The following is a description of a gene set: Human Gene Set: GOBP_MITOCHONDRIAL_FISSION The division of a mitochondrion within a cell to form two or more separate mitochondrial compartments. studied in species Homo sapiens, and this is the list of marker genes: BNIP3, STAT2, MCU, DDHD1, INF2, DNM1L, MTFR2, MIEF2, TMEM135 (NCBI Gene Id 65084), UCP2, MIURF, C11orf65, MARCHF5, AP3B1, AURKA, DDHD2, VPS35, MTFR1, PINK1, KDR, MTCH2, MIEF1, SPIRE1, RALA, PGAM5, DCN, MTFP1, GDAP1, MYO19, PPARG, LRRK2, FIS1, CYRIB, OPA1, MUL1 (mitochondrial E3 ubiquitin protein ligase 1), SLC25A46, RALBP1, MAPT, PRKN, COX10, MTFR1L, MFF (mitochondrial fission factor), IRGM